The following is a description of a gene set: from publication Yevshin I, Sharipov R, Kolmykov S, Kondrakhin Y, Kolpakov F (PMID 30445619) Mouse Gene Set: HSF1_TARGET_GENES Genes containing one or more binding sites for (Hsf1) in their promoter regions (TSS -1000,+100 bp) as identified by GTRD version 20.06 ChIP-seq harmonization. studied in species Mus musculus, and this is the list of marker genes: Mrpl16, Cfap126, Myl12b, Ddr2, Rpl36-ps2 (NCBI Gene Id 100043483), Krt19, Saraf, Hnrnpa2b1, Ahsa2, Mir1983, Dennd6b, 2610005L07Rik, Aloxe3, Ccn5, Actr5, Atp6v1g1, Radil, Spty2d1, Gm12518, Snhg7os, Slc27a4, Ube2d3, Sugp2, Sapcd2, 2310001K24Rik, Rplp2, Crygs, Psmg1 (proteasome (prosome, macropain) assembly chaperone 1), Hmga2, Kctd5, Psap, Pdzd2, Gm4285, Ccar1, Mgst2, Arpc2, Parp3, Lasp1, Gm26205, Kctd20, mt-Tl2, Elk4, Ptpa, Pex1, Gm25541, Gm14966, Eif2b4, Dcaf17, Slc35a5, Stc2, Cenpf, Mns1, Ap1g1, Npr1, Adcy7, Wdfy1 (WD repeat and FYVE domain containing 1), Vill, Rnu11, Rab31, 1700017G19Rik, Acat3, Slc4a4, Kif5b, Nbr1, Med13l, Ambra1, Med16, Rnf34, Gm22863, Ppp1r3c, Tbc1d17, Dlc1, mt-Ts2, Neat1, 2310015D24Rik, mt-Tl1, Birc5, Skp1, Nfya, Gm16170, Dedd, Ywhag, Bcor, Cstf1, Tbx15, Zfp661, H2ac7, Lsm5, Etfdh, Bst2, Ppp1r15b, Rny1, Ascc3, Pole4, Sec62, Wdr24, Sema6b, mt-Tt, Rprm, Jade1, Mir100hg, Adgra3, Mrps7, Hnrnpf, Or5t9, Gm13090, Actb, Psmf1, Abcg2, Arhgef1, Ifi203-ps, Ap4e1, Ppp6r3, Cep85, Cct3, Bnip1, Rab21, Ly6k, Dpm3 (dolichyl-phosphate mannosyltransferase polypeptide 3), Ccdc15, Ptov1, Sfi1, Cbx6, Ubxn4, Stag2, Wsb2, Hycc1, Proca1, Snord43, Acp6, Sat2, Dcp1a, A930018P22Rik, Uqcc4, Cep97, Cntnap5c (NCBI Gene Id 620292), Atf1 (activating transcription factor 1), Colec12, Prdx1, Pds5b, P4ha3, Sesn1, Rnu12 (NCBI Gene Id 19840), Cep57, Castor1, Gtf2h2 (general transcription factor II H, polypeptide 2), Havcr2, mt-Th, Lta4h, Serpinb6a, Tra2b, Rwdd3, Lrrc61, Slc11a2, Rbsn, Polr3gl, Arfip1, Wdfy2, Akr1c18, Gtf2f1, Tmod1, Ckap2, Csk, Mettl26, Prkag2, Bpifc, Gm15564, Tmed8, Pvt1, Eif4a2, Kansl3, Rtf1, Knl1, Clns1a, Esr1, Fgf2, Cys1, Spart, Vsig10, Lmf2, Tmbim4, H4c8 (NCBI Gene Id 69386), Fbxo36, Ubqln1, Synj2, Jmjd6, Fgfr1op2, Pitpnm2os1, Atp8b2, Med23, B4gat1, Cpsf1, Prdm4, Gm4890, Arl6ip1, Ier5l, Arc, 1700028E10Rik, Mthfs, Dync2h1, Cep57l1, Gm43838, Igkv8-19, Lurap1l, P4ha1 (NCBI Gene Id 18451), Mrpl43, Slc16a13, Ccnd3, Stard6, Krtap4-25, Malat1, Lrrc28, Fech, Timm9, Cald1, Gm52993 (predicted gene, 52993), Pigz, Jarid2, Usp3, Fgfrl1, Aqp3, Klhl23, 4933425M03Rik, Arhgap10, Oxsr1, Abhd3, Plod1, Mir5135, Nus1, Zfp560, Tubgcp4, Rpl41, Gm15459 (NCBI Gene Id 727711), Cpped1, Mboat7, S100a10, C920006O11Rik, Rfc4, Tpt1, Mettl8, Atp2c1, 8430436N08Rik, Ankrd26, Gm24641, Tcl1b1, Capn3, P4hb, Ddx52, Nme2, Mrps35, Cnep1r1, Gm24044, Dusp14, Plin2, Gm24086, Amot, Palb2, Alkbh5, Prcc (NCBI Gene Id 94315), Ptpn13, Rps18, 2310068J16Rik, Dctn5, Zbtb7b, Pantr2, Wbp2, Clptm1, 1700030C12Rik (RIKEN cDNA 1700030C12 gene), Dzank1, Ppp2cb, Gm33866, Znfx1, Zfp64, Atg3, Son, Anapc16, Ciao2a, Psmg3, Suv39h2, Dnajc3, Hikeshi, Rfx1, Dact2, Upk3bl, Tenm3, Emc6, Tmem167, Atosa, Slc35e2, Cish, Lhfpl2, Cpne5, Tpgs1, Sphk2, Slc1a7, Timm10, Mfsd13b, Slc31a2, Pyroxd1, Oxct1as, Slc35c1, Mcm4, Psma7, Isyna1 (NCBI Gene Id 71780), Setd4, Herpud1, Slc37a2, Sf3b2, Opn1sw, Creb3l3, Hspb8, H2bc18, Ctr9, Plekhf2, Asap1, 2310015A10Rik, Spen, Syt8, Gm12038, Utp23, Lgals7 (NCBI Gene Id 16858), Rhbdl3, BC065403, Snora17, Aaas, Zfp354b, Rexo2, Dbndd2, Htra2, Serpinh1, Gm10222, Efnb1 (ephrin B1), Mcoln1, Slc25a29, Ncam1, Ache (NCBI Gene Id 11423), Tut1, Vps72, 4930539J05Rik, Hmg20a, Ubfd1, Pdxk-ps, Plod2, Azi2, Parl, Abce1, Zfp516, Gnb1, Tomm22, Mkks, 6330549D23Rik, Ccdc107, Itga2b, Cdk5, Bora, Cdca2, Mtx1, Mapk6, Myrf, Orc5, mt-Ty, Naa50, Rny3, Mmp2, Cacna1c, Ywhah, Rragc, Gm16201, D330050G23Rik, Meg3, Zbtb45, Slc5a12, Hspd1, Mir8105, Zmynd8, Ski, Celf5, Dynll1, mt-Nd5, Zfp335os, Atad2, Coa3, Ggnbp1, Peak1, Pdia3, Edn2, Fem1b, Ankrd40, Sec13, Agbl5, Dnajb2, 9930022D16Rik, Galnt4, Psmd3, Ms4a4c, mt-Te, Rgs12, BC065397, Vipas39, Gm11205, Anp32a, Pip5k1a, Scamp3, A330048O09Rik, Umps, Hinfp, mt-Ti, Rbm48, Trip12, Trmt1l, Med24, Mir345, Tbc1d31, Eif4g2, Rangap1, Higd2a, Golga1, Mdh1b, Ears2, Capg, Vcam1, Ptpn22, Usp36, Dnm1l, Trafd1, Rere, Gm26802, Rpl3, Rab11a, C230035I16Rik, Hspb2, Tmem177, mt-Tn, Mrpl39, Fitm2, Cct5, Hsp90ab1, Zfp46, Xirp1 (xin actin-binding repeat containing 1), BC048559, Mt2, Dram2, Atg7, Wdr1, Trim2, Tns3, Dut, Ddx23, St6galnac6, Aco1, Mir207, mt-Tp, Ngef, Bpnt1, Gm17473, Bag3, Rpl28, Gm8357, Ube2b, 1700065J11Rik, Taf6, Tcirg1, Dbn1, Gm5464, Peli1, Oaz1, Phactr4, Cpn1, Magoh, Fbxo47, Gtf3c6, Faddos, 1700061I17Rik, Igf2bp1, Tk1, Gprasp2, Mdga1, Gm8818, Gdi1, C1galt1c1, Cltc, BB557941, Poldip3, Nutf2, Pot1a, Krtap1-5, Maged1, Zscan29, Amotl2, Atp5pb, 4930563E18Rik, Zfand2a, Zfp623, Ptges3, Plekhg2, Trim32, Zfand1, Polr3c, Cryab, Unc93b1, Gm31266, 1810012K16Rik, Mir34b, Zc3hav1, Gm15764, Arsk, Fam131b, Pldi, Mthfr, Taok3, Laptm4a, Slc25a42, Sh3d19, H2bc7, B4galt5, Krt13, Plin3, Atpsckmt, Nudt13, mt-Tc, Map1a, Pias2, Tgif1, Aldh1a2, Plscr4, Mt1, mt-Ta, Sec24c, Ptpn1 (protein tyrosine phosphatase, non-receptor type 1), Mmaa, Ier5, Ddx47, mt-Tq, Rac1, Vwa1, Gm40190, Fcrl1, Rnf115, Gm5444, Mertk, Gm5129, Cux2, mt-Tm, Ttc41, Idh1, Dedd2 (death effector domain-containing DNA binding protein 2), Psph, Pax6os1 (NCBI Gene Id 402728), Cbx4, B130034C11Rik, Fam161a, Abcd1, Gm16253, Nme1, Tbl1x, Wnk1, Mir214, mt-Cytb, Pdzd7, Mark4, Fastkd2, Dnaaf3, Oxct1, Dnajb5, Gm15941, Ang (NCBI Gene Id 11727), Ccdc117, Thbs3, Lipe, Acaa1a, Foxj1, Slc39a3, Mks1, Hspe1, Pik3ca, C630043F03Rik, Fkbp4, Ywhae, Rbms2, Sgf29, Lrsam1, Mir8111, Tpi1, Ift140, Kctd18, Ccnl2, Frmd8os, Laptm4b, Ggh, Prkar1b, Snx1, Polg, Cct6a, Fchsd2, Catsper2, Eno2, Erp44, Kcnq5, Eif5, Pierce1, Prmt5, Cstad, Csrnp2, Elovl5, Mrgprf, Hspa1b, Tmem33, Gabre, Vpreb1a, Zfp949, U2surp, Nudc, Fmc1, D730003I15Rik, Trbv10, Slc4a2, Tmbim1, Tbccd1, Mir5136, Peli3, Flnc, Mga, Poc1a, Frmd4a, Rbm25, Hivep1, Rpl6 (NCBI Gene Id 19988), Sh3gl1, B9d1os, Gm14161, Tonsl, Map2k4, Sacm1l, Zcchc8, Atp6v1h, Ndufs7, Wnt1, Mm2pr, Aox1, Naa30, Frmd5, Mcm3ap, 4930503L19Rik, Parvb, Aup1, Cyrib, Etv6, 2700029L08Rik, Phlda1, Atic, Arl6ip4, Coasy, Gm17501, Mtpn, Wdr77, Gm37294, Cct4 (NCBI Gene Id 97705), Cebpb, Atp5f1c, Nr1h3, Rbm38, 4833417C18Rik, 5730596B20Rik, Gpbp1, 1700064H15Rik, Tns1, Ccnl1, Ifitm2, Dnajb11, Dnmt3aos, Gm11110, Setx, Gm1070, Siae, Rps13, mt-Nd2, Ankrd29, Tpbg, Prickle1, Tmem80 (transmembrane protein 80), Ubb, Glp1r, Frat2, Traf3, Cflar, 4930542C12Rik (NCBI Gene Id 67648), Prkag3, Zcwpw2, Snord2, Ahsa1, Smpdl3b (NCBI Gene Id 68772), Ascc1, Them4, Fhod1 (formin homology 2 domain containing 1), Ncln, Slc66a1, Arl4aos, Hspa1l, mt-Tw, Mir125a, Gm12279, St13, Dnaja4, Mndal, Psmb3, Swt1, Sprr1a, Brpf1, Rpl22, Snora57, Mettl23, Aptx, Chchd2, Glt28d2, Cybc1, Kntc1, Snrpb2, Hsp90aa1, Gprasp1, Acot7, Stat6, Ints2 (integrator complex subunit 2), Vps52, Tent5a, A530053M12Rik, Gm829, Tor4a, Myl12a, Rpl38, Dnajb4, Nfkb2, Duoxa1, Dclre1a, Gm16508 (NCBI Gene Id 100038440), Ablim1, Sucla2, C1rl, Sema4b, Junos, Hsph1, Oga, Dctn6, Pnrc1, Specc1, Chka, Ctnna3, Samd15, Tfeb, Tm7sf3, 9430015G10Rik, Galnt13, Mir3109, Macrod1, Acp2, Tcea1, 5430402E10Rik, Rnf126, Stim1, Rbm8a, Gm11476, Prkdc, Mrps33, Fbxo42, Cyb561, Gm15413, Cxcl10, Morc4, Htt, Morf4l2, Tmf1, Mir34c, Rpl7l1, Tia1, Zmym6, Ccdc59, Focad, Mir6236, Ifi203, Limk1, Sidt2, Fbxl14, Duxf1, Afmid, Gm13783, Hspbp1, Wee1, Il1rl1, Gjb4, Zfand5, Tsacc, Rbx1 (ring-box 1), Gm13830, Edf1, Mov10, Fkbp8, 4930447M23Rik, Arl4a, Lyrm7, Kin, Cacybp, Cisd1, Dnajb1, Grsf1 (NCBI Gene Id 97246), Xrcc4, 6030443J06Rik, Cdr2, Ly6m, Ino80, 4930594M22Rik, LTO1, Slc5a3, Emid1, Spaca6, Cenpk (centromere protein K), Itga6, Nr2f2, Usp13, Trim26, Cep295nl, Hspa4, mt-Nd6, Tspyl2, Rcan2, Gm16041, Zbtb38, Set, Rps9, Dus1l, Tanc1, Gas2l3, Fbxl18, Sod1, Slc15a3, Fscn1, Commd3, Pfkl, Secisbp2l, Hspa4l, Ccdc62, Ebf1, Zdhhc2, Anp32e, Xpnpep3, Ergic1, Sf1, Chordc1, Kctd9, H4c6, mt-Tv, Lingo3, Des, Slc29a1, Hspa1a, Gm15071, P4ha2, Ttc17, Dip2a (disco interacting protein 2 homolog A), Tex2, Tmem63b, Fam76b, Hspb1, Micos13, Ppwd1, Ndufs8, Sinhcaf, Klc1, Atp13a3, Dnajb6, 9330136K24Rik, Ilf2, Ist1, Nup58, Sphk1, Pim3, Smarcc2, A630095N17Rik, Zfp329, Prrg4, Krtap2-4, Mrpl18, Gcnt2, Cd44, Zfp760, Fmnl1, Mob4, Polr3f, Mdm2, Gm17835, Asb18, Med4, Sun1, Gng7, Irf2bp1, Gga3, Pla2g6, Uspl1, Stk11ip, H2-D1, Stip1, Gm17382, Ipo7, Azin1, Mir22, Gm4894, Brf1, Slx4ip, Atp6v1a, Nr1h2, Colgalt1, B9d1, Ehmt1, Cmklr1, Yap1, Zswim1, Phrf1, Cfap418, Sec31a, Zfpm2, Phf3, Zfp827, Fbxo31, Apba3, Ube2g2, Thtpa, Naa16, Rhoj (NCBI Gene Id 80837), Mynn, Rnf181, Pik3ip1, Cct8, Gm5493, Gm16838, Zmiz2, 1700120B22Rik, Mettl25, Cetn4, Phykpl, Gm13421, Hspa8, Tmie (transmembrane inner ear), Stox2, Cerkl, Ppm1b, Gm11527, 9130213A22Rik, Parp2, Neurl1a, Tcp1, Larp7, 1700047K16Rik, Btbd19, Hspa9, Pradc1, Fxr1, Ints5, Actr3, Arhgef12, Wbp4, 1700030J22Rik, Slc38a2, 4933417C20Rik, Nfe2l1 (nuclear factor, erythroid derived 2,-like 1), Traf4, Tsen34, Dennd1b, Apoh, Fas, Dnaja1, Ociad2, Rbm42, Pafah1b1, Snx17, Ipp, Abcc5, Timm13 (NCBI Gene Id 52584), Trim65, Gm11292, Art3, Abt1, Mtf1, Ankrd34a, Eif2s2, Deaf1, Gm31314, Tle1, Clcn2, Ints15, Mrps6, Msh3, Gm10433, 9230111E07Rik, Anapc10, Sesn3, Papola, Ltbp1, Rpl18, Adi1, Rsf1os2, Serpinb6b, Zfp846, Lhx9 (NCBI Gene Id 98737), Echdc1, Rnase4, Usp30, Muc13, Ran, Skic3, Zfas1, Top3b, Polr2h, Zfp9, Foxp1, Rsrp1, Bmal1, Tmsb10 (thymosin beta 10), Arid4a, Dnajb12, Tecpr1, 1700067G17Rik, Unc45b, Mrpl44, Lcor, Gm17116, Rpl30-ps6, Elk3, Slc43a2, Dcun1d5, Clu (NCBI Gene Id 28201), Axdnd1, Sync, Polr3e, Ubc, Zfp335, Mir8098, Ankrd54, mt-Rnr2, Adamts1, 2700049A03Rik, Gm10069, Slc25a15, mt-Nd1, Ddx59, Gm25878, Ptger4, Ankrd46, Phc3, Cbx3 (chromobox 3), Jun, Trdmt1, Phb1, Lims1, Lenep, Ccn1 (NCBI Gene Id 99596)